The following is a description of a gene set: studied in species Homo sapiens Pathway Definition from KEGG: PORCN -> WNT Human Gene Set: KEGG_MEDICUS_REFERENCE_WNT_SIGNALING_MODULATION_WNT_ACYLATION Wnt signaling modulation, Wnt acylation. Pathway ID: N01443. Pathway type: Reference. Pathway class: nt06505 WNT signaling., and this is the list of marker genes: WNT1, WNT3, WNT5B, WNT2B, PORCN, WNT8A, WNT10A, WNT7B, WNT10B, WNT2, WNT9B, WNT6, WNT16 (NCBI Gene Id 51384), WNT5A, WNT3A, WNT7A, WNT9A, WNT8B, WNT4